Given this list of marker genes MAPKAPK3, KRAS, MAPKAPK2, RALB, SRC, RALGDS, MAPK11, NRAS, MAPK12, MAPK14, RALA, HRAS, MAPK13, here is a description of the gene set: part of: Signalling to RAS Reactome Pathway: p38MAPK events species: Homo sapiens NGF induces sustained activation of p38, a member of the MAPK family (Morooka T, Nishida E, 1998). Both p38 and the ERKs appear to be involved in neurite outgrowth and differentiation caused by NGF in PC12 cells. As a matter of fact, PC12 cell differentiation appears to involve activation of both ERK/MAPK and p38. Both ERK/MAPK and p38 pathways contribute to the phosphorylation of the transcription factor CREB and the activation of immediate-early genes (Xing J, 1998). p38 activation by NGF may occur by at least two mechanisms, involving SRC or MEK kinases.